Given this list of marker genes Casp3, Ndn, Rapgef2, Bcar1, Ntrk1, Tmem108, Ppp2r5b, Rap1a, Ntf5, Spry1, Gfra1 (NCBI Gene Id 14585), Raf1, Ngf, Lmtk2, Cd2ap, Ulk1, Coro1a, Ntf3, Src, Akt1s1, Zdhhc17, Ptpn11, Hap1, Ptprf, Bex1, Zfyve27, Agtr2, Bdnf, Ntrk3, Dok5, Rapgef1, Sort1, Shoc2, Sos1, Ddit4, Kidins220, Magi2, Slc9a6, Ppp2r5d, Cyfip2, Ntrk2, Spry2, Wasf1, Cyfip1, Agt, Sh3glb1, here is a description of the gene set: studied in species Mus musculus The series of molecular signals initiated by neurotrophin binding to its receptor on the surface of a target cell, and ending with the regulation of a downstream cellular process, e.g. transcription. Neurotrophins are a family of secreted growth factors that induce the survival, development, and function of neurons. Mouse Gene Set: GOBP_NEUROTROPHIN_SIGNALING_PATHWAY